The following is a description of a gene set: Mouse Gene Set: MIR_6905_3P from publication Chen Y, Wang X (PMID 31504780) studied in species Mus musculus Genes predicted to be targets of miRBase v22 microRNA mmu_miR_6905_3p in miRDB v6.0 with MirTarget v4 prediction scores > 80 (high confidence targets)., and this is the list of marker genes: Tulp4, Zgrf1, Slf2, Sp3, Syde2, Vps53, Nop10, Tll1, Qki, Trim2, Nyap2, Sap30, Nfat5, Gabpa, Gm527, Klhl34, Smc3, Plk2, Tpd52, Jrkl, Frk, Slc12a6, N4bp2l1, Hdac9, Ntn1, Arf4, Zfp36l1, Jup, Rbm47, Gadd45a (NCBI Gene Id 13197), Serp1, Id1, Trim33, Onecut2, Dach2, Catspere2, Casz1, Nkd1 (NCBI Gene Id 93960), Chm (CHM Rab escort protein), Dlgap4, Zfp109, Dpysl3, Tcerg1, Dpp10, Ripk2, Pheta2 (NCBI Gene Id 338368), Fam169a, Phip, Sp1, Ptpn20, Tex11, Rfx5, Lhx9, Acsl3, B3galnt1, Dusp6, Zfand5, Nufip2, Rfx7, Thsd7a, Rem2, Uqcc5, Golga1, Poglut2, Sytl5, Metrnl, Dach1 (dachshund family transcription factor 1), Gucy1a1, Kbtbd6, Heatr6